The following is a description of a gene set: species: Homo sapiens The process in which a relatively unspecialized cell acquires specialized features of a bipolar cell, the last neuron to be generated in the retina. Human Gene Set: GOBP_RETINAL_BIPOLAR_NEURON_DIFFERENTIATION, and this is the list of marker genes: PRDM1, BBS10, GNAT2, NAGLU, VSX2, RHO, CABP4, VSX1, NDP, ZHX2, IRX5